Given this list of marker genes PLAAT2, PLAAT4, PLAAT5, ABHD4, NAAA, PLAAT3, PLAAT1, NAPEPLD, PLA2G4E, here is a description of the gene set: The chemical reactions and pathways involving N-acylphosphatidylethanolamines. An N-acylphosphatidylethanolamine is a phosphatidylethanolamine substituted at nitrogen by an acyl group. species: Homo sapiens Human Gene Set: GOBP_N_ACYLPHOSPHATIDYLETHANOLAMINE_METABOLIC_PROCESS